The following is a description of a gene set: studied in species Mus musculus Cluster P4 of genes with similar expression profiles in peripheral T lymphocytes after FOXP3 loss of function (LOF). Human Gene Set: GAVIN_FOXP3_TARGETS_CLUSTER_P4 from publication Gavin MA, Rasmussen JP, Fontenot JD, Vasta V, Manganiello VC, Beavo JA, Rudensky AY (PMID 17220874) Regulatory CD4+ T cells (Tr cells), the development of which is critically dependent on X-linked transcription factor Foxp3 (forkhead box P3), prevent self-destructive immune responses. Despite its important role, molecular and functional features conferred by Foxp3 to Tr precursor cells remain unknown. It has been suggested that Foxp3 expression is required for both survival of Tr precursors as well as their inability to produce interleukin (IL)-2 and independently proliferate after T-cell-receptor engagement, raising the possibility that such 'anergy' and Tr suppressive capacity are intimately linked. Here we show, by dissociating Foxp3-dependent features from those induced by the signals preceding and promoting its expression in mice, that the latter signals include several functional and transcriptional hallmarks of Tr cells. Although its function is required for Tr cell suppressor activity, Foxp3 to a large extent amplifies and fixes pre-established molecular features of Tr cells, including anergy and dependence on paracrine IL-2. Furthermore, Foxp3 solidifies Tr cell lineage stability through modification of cell surface and signalling molecules, resulting in adaptation to the signals required to induce and maintain Tr cells. This adaptation includes Foxp3-dependent repression of cyclic nucleotide phosphodiesterase 3B, affecting genes responsible for Tr cell homeostasis., and this is the list of marker genes: SYT11, HSPA1B, KIAA1671, ARHGAP29, CAPN3, TWSG1, GPR83, TNFRSF4, IL2RA, GPRC5B, CD79B, ATP8B4, SWAP70, MYO1C, VAV2, ETFBKMT, IL2RB, EPAS1, FRMD4B, TNFRSF9, NRP1, CTLA4, MMD, ALS2CL, STON1, MAP3K8, NIBAN1, RFLNB (NCBI Gene Id 359845), IKZF2, STX11, NCF1, GPR15, CDKN2C, RAPGEF4, AFP, NOL4L, FAH, CD83, SEMA4F, SH3BGRL2, PXYLP1 (NCBI Gene Id 92370), IL1RL1, PLAGL1, SEMA4A, GPLD1, PDK1, ADH1A, NEB, LCLAT1, FASLG, RAMP3, TIAM1, CAPG, CTTN, APOL1, LYPD6B (LY6/PLAUR domain containing 6B), ENC1, NFIL3, PPM1L, CHD7, IL1RL2, SLC16A5, SLC22A15, PENK, AOPEP, CD81, DAPL1, CNGA1, TMIE, OSBPL3, ANXA4, ACSBG1, RRAGD, THEMIS, MXD1, MCUB, PRC1, SOAT1, HOPX, MBNL3, GADD45B, BACH2, GGT5, ST3GAL6, ITGAE, TTC7B, FOXP3, ALCAM, RGCC, ITIH5, PMAIP1, IL1R2, TNFRSF1B, TNFRSF18, PIM1, GBP6, RILPL2, PRKAR1B, GSTO1, TANC1, MYO10